Given this list of marker genes CSPP1, CDH3, C1QTNF5, TIMP3, KIAA0586, CYP4V2, here is a description of the gene set: Deposits accumulating between the outer retina and the retinal pigment epithelium. Human Gene Set: HP_SUBRETINAL_DEPOSITS Subretinal deposits species: Homo sapiens